Given this list of marker genes PLA2G4C, GPCPD1, here is a description of the gene set: Lysophosphatidylethanolamine (LPE) is hydrolyzed by phospholipases to produce glycerophosphoethanolamine (GPETA) which is in turn hydrolyzed by glycerophosphocholine phosphodiesterase to produce ethanolamine (ETA) and glycerol-3-phosphate (G3P). part of: Glycerophospholipid biosynthesis Reactome Pathway: Hydrolysis of LPE species: Homo sapiens